Given this list of marker genes CLASP1, C19orf84, ARPC2, CDKN2D, TULP4, here is a description of the gene set: studied in species Homo sapiens Human Gene Set: MIR3197 Genes predicted to be targets of miRBase v22 microRNA hsa-miR-3197 in miRDB v6.0 with MirTarget v4 prediction scores > 80 (high confidence targets). from publication Chen Y, Wang X (PMID 31504780)